The following is a description of a gene set: Binds to and stops, prevents or reduces the activity of a lipase, an enzyme that catalyzes of the hydrolysis of a lipid. studied in species Mus musculus Mouse Gene Set: GOMF_LIPASE_INHIBITOR_ACTIVITY, and this is the list of marker genes: Apoc3, Apoc1, Faf2, Apoc2l, Scgb1a1, Pinlyp, Angptl3, Anxa1, Anxa2, Apoa2, Apoa1, Apoc2, Ppt1, Anxa3